Given this list of marker genes Dlg5, Calb1, Wnt7b, Pax8, Pkd1, Akr1b1, Shh, Aqp2, Pax2, Ptch1, here is a description of the gene set: species: Mus musculus Mouse Gene Set: GOBP_METANEPHRIC_COLLECTING_DUCT_DEVELOPMENT The process whose specific outcome is the progression of a collecting duct in the metanephros over time, from its formation to the mature structure. The collecting duct responds to vasopressin and aldosterone to regulate water, electrolyte and acid-base balance. The collecting duct is the final common path through which urine flows before entering the ureter and then emptying into the bladder.